Given this list of marker genes Lrif1 (NCBI Gene Id 99637), Macroh2a1, H3f3a, Smchd1, H2az1, Macroh2a2, here is a description of the gene set: Mouse Gene Set: GOCC_BARR_BODY species: Mus musculus A structure found in a female mammalian cell containing an unpaired X chromosome that has become densely heterochromatic, silenced and localized at the nuclear periphery.